The following is a description of a gene set: studied in species Mus musculus Mouse Gene Set: GOBP_POSITIVE_REGULATION_OF_PEPTIDYL_THREONINE_PHOSPHORYLATION Any process that increases the frequency, rate or extent of peptidyl-threonine phosphorylation. Peptidyl-threonine phosphorylation is the phosphorylation of peptidyl-threonine to form peptidyl-O-phospho-L-threonine., and this is the list of marker genes: Tnks1bp1, Wnt5a, Stox1, Cab39, Irgm2, Cemip, App, Ube2k, Trpc6, Plk1, Ripk2, Gsk3b, S1pr2, Prkag2, Adcy10, Wnk3, Igtp, Trpc5, Rptor, Gsk3a, Chi3l1, Irgm1 (immunity-related GTPase family M member 1), Phip, Mapk1, Met, Trim6, Egf, Sphk1